Given this list of marker genes GUSB, NCCRP1, EDEM2, HPSE, ADAMTS12, EDEM3, MANBA, CST3, HYAL1, CELA1, MAN1A1, MIR181B1, ADAMTS4, FBXO27, EDEM1, HEXB, NAGLU, FBXO17, CTSL, SGSH, NGLY1, HGSNAT, GLB1, NEU4, HEXA, FBXO44, MAN1B1, FBXO6, STT3B, GPC1, OGA, NEU2, FBXO2, IDUA, GNS, IDS, HYAL4, BTK, MMP12, here is a description of the gene set: Human Gene Set: GOBP_GLYCOPROTEIN_CATABOLIC_PROCESS The chemical reactions and pathways resulting in the breakdown of a glycoprotein, a protein that contains covalently bound glycose (i.e. monosaccharide) residues; the glycose occurs most commonly as oligosaccharide or fairly small polysaccharide but occasionally as monosaccharide. studied in species Homo sapiens